Given this list of marker genes PDGFRL, HAS2, SERPINB2, CLCN4, FABP5, RBPMS, PPP2R3A, CNN1, STAMBP, SOX4 (NCBI Gene Id 6659), PLPP3 (phospholipid phosphatase 3), CXCR4, COL1A2, RAMP2, ANOS1, CLCN6, CAND2, GULP1, DLC1, DOK5, LPXN, HMOX1, ROR1, IRF5, HMGN3, ENPP2, PRKCZ, VCAN, SYNM, VLDLR, MAP2K5, SSBP2, PTN (NCBI Gene Id 5764), BMP4, here is a description of the gene set: Xeroderma pigmentosum (XP) and trichothiodystrophy (TTD) syndromes are characterized by deficiency in nucleotide excision repair pathway, but with distinguished clinical manifestations. While XP patients exhibit a high frequency of skin cancer, TTD patients are not cancer prone. The relation between lack of DNA repair and their clinical manifestations was investigated through analysis of the transcriptional profile of 12,600 transcripts in two isogenic cell lines with different capabilities of DNA repair. These cell lines result from a stable transfection of the XPB-TTD allele into XP complementation group B fibroblasts, from an XP patient who also have clinical abnormalities corresponding to Cockayne's syndrome (CS). The microarray assays performed under normal growth conditions showed the expression of distinct groups of genes in each cell line. The UVC-transcription modulation of these cells revealed the changes in 869 transcripts. Some of these transcripts had similar modulation pattern in both cells, although with eventually different time patterns for induction or repression. However, some different 'UVC signature' for each cell line was also found, that is, transcripts that were specifically UV regulated depending on the DNA repair status of the cell. These results provide a detailed portrait of expression profiles that may potentially unravel the causes of the different phenotypes of XP/CS and TTD patients. species: Homo sapiens from publication da Costa RM, Riou L, Paquola A, Menck CF, Sarasin A (PMID 15608684) Human Gene Set: DACOSTA_ERCC3_ALLELE_XPCS_VS_TTD_DN Genes down-regulated in fibroblasts expressing different mutant forms of ERCC3: XP/CS (xeroderma pigmentosum (XP) and Cockraine's syndrome (CS)) vs TTD (trichothiodystrophy).